Given this list of marker genes GIMAP1, ZNF177, GNRHR, SRP68, METTL21A, ZNF576, KRBOX4 (NCBI Gene Id 55634), KERA, LINC01530, FAM120B, KASH5, FOS, NEK2, PLXNB1, NOVA1, NAIF1, DUSP6, GUCY1B2, ZNF559, GEMIN5, SLC35B3, DDIAS, FRMD5, C2CD6, CSE1L, PEX1, GIMAP2, DNAL1, NAPEPLD, NUP37 (nucleoporin 37), TSHZ1, ZNF70, DROSHA, MAIP1, GIMAP6, UTP14C, SNTG2-AS1, GXYLT1, POLR1G, RIPK4, ZC3H12B (zinc finger CCCH-type containing 12B), CMTR2, ZNF260 (NCBI Gene Id 339324), ZNF850, TIMM21 (NCBI Gene Id 29090), TTI1, DNAAF10, FANCF, PAAF1, NMNAT1, PUS7L, GSPT2, UMPS, UBE2DNL, PNPLA4, POP1, SPTY2D1, SSR4P1, CYP4F30P, CKMT2, RMI1, GET1, DPP10-AS1, CEACAM3, SULT1E1, PHF14 (NCBI Gene Id 9678), PAQR8 (NCBI Gene Id 85315), CNFN, AGGF1, HHEX, SYNE2, RSPH4A, ERMARD, PARS2, P2RY13, CETN3, MTRES1 (mitochondrial transcription rescue factor 1), RCSD1, FANCB, RPP40 (NCBI Gene Id 10799), WDR53, HJURP, TRMT12, ZNF818P (NCBI Gene Id 390963), DCP1B, NCDN, ZNF544, SLIT2-IT1, MMACHC, SASS6, ARHGEF28, ZNF285, ZSCAN32, RMND5B, CBR3-AS1, INTS8, CHST15, PSRC1, ANP32A, FHL1P1, LYPD4, ZSCAN29, ZNF561, RDH8, CSTF1, TCN1 (NCBI Gene Id 6947), DAAM2, ASF1A, ZNF583, RPE, BTNL9, PRND, ZNF234, TLR6, GIMAP7, NIFK-AS1, DBR1 (debranching RNA lariats 1), TNRC18, KRT79, CYREN, EFCAB7, SLC39A3, COX6A2, C2orf42, DZIP3, MRPS31, SALL3, HAUS6, TBC1D14, AP2A1, MTNAP1, CCDC51, KBTBD7, RUNDC1, CCDC66, IFNGR1, ORC5, NLRP5, NFE2L1, NUDT6, MAPK14, ZNF45, URB1, BORA, TTI2, HMG20A, PDCD2L, NAV2, ERO1A, CPLANE2, VXN, ATP23, HMGCL, RGS4, TNRC6A, ZNF30, POLI, FUT11, IL21R, FBXL4, OXSM, CEP85, UTP23, KAT14, CREB3L1, ZNF485, ATF6B, ACVR1B, GOLGA1, C15orf61, CHRND, ZMYM1, TLR1, ZFYVE26, TRIM27, LEFTY2, MS4A2, RIOK2, SEC22A, CCDC13, SPRR2B, OR5J2, ZNF319, HEATR6, MRPS26, ZBTB9, HNF4G (hepatocyte nuclear factor 4 gamma), BCHE, RFPL1S, MLH3, ZFP62, SMG8, GIMAP5, SPATA16, GLIS3-AS1, ACHE, PRIM1, here is a description of the gene set: from publication Zaslavsky E, Hershberg U, Seto J, Pham AM, Marquez S, Duke JL, Wetmur JG, Tenoever BR, Sealfon SC, Kleinstein SH (PMID 20164420) Genes up-regulated in comparison of control conventional dendritic cells (cDC) at 0 h versus cDCs infected with Newcastle disease virus (NDV) at 2 h. species: Homo sapiens The dendritic cell (DC) is a master regulator of immune responses. Pathogenic viruses subvert normal immune function in DCs through the expression of immune antagonists. Understanding how these antagonists interact with the host immune system requires knowledge of the underlying genetic regulatory network that operates during an uninhibited antiviral response. In order to isolate and identify this network, we studied DCs infected with Newcastle Disease Virus (NDV), which is able to stimulate innate immunity and DC maturation through activation of RIG-I signaling, but lacks the ability to evade the human interferon response. To analyze this experimental model, we developed a new approach integrating genome-wide expression kinetics and time-dependent promoter analysis. We found that the genetic program underlying the antiviral cell state transition during the first 18-hours post-infection could be explained by a single regulatory network. Gene expression changes were driven by a step-wise multi-factor cascading control mechanism, where the specific transcription factors controlling expression changed over time. Within this network, most individual genes are regulated by multiple factors, indicating robustness against virus-encoded immune evasion genes. In addition to effectively recapitulating current biological knowledge, we predicted, and validated experimentally, antiviral roles for several novel transcription factors. More generally, our results show how a genetic program can be temporally controlled through a single regulatory network to achieve the large-scale genetic reprogramming characteristic of cell state transitions. Human Gene Set: GSE18791_CTRL_VS_NEWCASTLE_VIRUS_DC_2H_UP